Given this list of marker genes Prkg2, Plcb4, Abl1, Mical2, Mapkapk3 (mitogen-activated protein kinase-activated protein kinase 3), Dusp2, Map3k1, Pebp1, Arrb2, Mapkapk2 (NCBI Gene Id 98242), Dusp10, Tpr, Prkg1, Ptafr, Tab1, Pea15b-ps, Mapkapk5, Mapk7, Dusp1, Dusp16, Ep300, Cdk5rap3, Stau2, Nbr1, Ptprj, Sirt1, Iqgap1, Prmt1, Tnip1, Mapk14, Ace, Nfatc1, Ppm1d, Gch1, Atf7, here is a description of the gene set: Mouse Gene Set: GOMF_MITOGEN_ACTIVATED_PROTEIN_KINASE_BINDING Binding to a mitogen-activated protein kinase. studied in species Mus musculus